Given this list of marker genes MIR221, P2RY12, P2RX4, MIR222, CCL3, CSF1, TREM2, RRAS2, CRKL, CX3CL1, CCR2, here is a description of the gene set: studied in species Homo sapiens Any process that activates or increases the frequency, rate or extent of glial cell migration. Human Gene Set: GOBP_POSITIVE_REGULATION_OF_GLIAL_CELL_MIGRATION